Given this list of marker genes Vcp, Psmd1, Spop, Psmc4, Psma2, Psma4, Psmc1, Psma7, Sel1l, Psmd13, Cdk4, Tmem258, Csnk2b, Cul1, Pdcd1lg2, Psmb7, B3gnt3, Cd274, Ost4, Psmc6, Psmd7, Ubb, Prkag3, Psma5, Psma1, Dad1, Derl3, Erlec1, Psma3, Psmb4, Psmd12, Tusc3, Psmb5, Psma6, Prkag1, Psmc2, Rps27a (ribosomal protein S27A), Mib2, Stt3a, Ccnd1, Psmc5, Psmb6, Stt3b, Psmd6, Derl1, Ddost, Psmc3, Pdcd1, here is a description of the gene set: electronically inferred by orthology from the curated human pathway part of: Regulation of PD-L1(CD274) expression species: Mus musculus Reactome Pathway: Regulation of PD-L1(CD274) Post-translational modification This event has been computationally inferred from an event that has been demonstrated in another species.<p>The inference is based on the homology mapping from PANTHER. Briefly, reactions for which all involved PhysicalEntities (in input, output and catalyst) have a mapped orthologue/paralogue (for complexes at least 75% of components must have a mapping) are inferred to the other species.